The following is a description of a gene set: Mouse Gene Set: GOBP_REGULATION_OF_ICOSANOID_SECRETION Any process that modulates the frequency, rate or extent of the controlled release of an icosanoid from a cell. species: Mus musculus, and this is the list of marker genes: Atp5pf, Tnfrsf11a, Cyp4a31, Pla2g3, Hrh2, Mif, Cyp4a32, Pla2g6, Avpr1b, P2ry2 (purinergic receptor P2Y, G-protein coupled 2), Mapk9, Acsl4, Tnfsf11, Oxt, Map2k6, Cyp4a10, Pla2r1, Edn1 (NCBI Gene Id 13614), Pla2g10, Il1a, Hrh3, Ntsr1, Ptges, Agtr2 (angiotensin II receptor, type 2), Pla2g4a (phospholipase A2, group IVA (cytosolic, calcium-dependent)), Sstr4, P2rx7, Syk, Il1b